Given this list of marker genes ABCB1, UGT1A3, SLCO1B3, PON1, CYP3A4, PON3, SLCO1B1 (solute carrier organic anion transporter family member 1B1), ABCC2, SLCO2B1, here is a description of the gene set: Human Gene Set: REACTOME_ATORVASTATIN_ADME species: Homo sapiens Atorvastatin ADME